Given this list of marker genes Ccdc9b, Glcci1 (glucocorticoid induced transcript 1), Deup1, Thsd7a, Maml3 (NCBI Gene Id 99860), Coq10a, Crot, Ppargc1a, Tead1, Col5a1, Dpysl3 (dihydropyrimidinase-like 3), Jmy, Tanc2 (tetratricopeptide repeat, ankyrin repeat and coiled-coil containing 2), Xirp2, Appl1, Pcdhga12, Utp11 (NCBI Gene Id 67205), Irak1bp1, Ppp3r1, Zfp40, Slc25a17, Sh3pxd2a, Rnf222, Rcan2, Ogt, Zfp329, Nr2e1, Ccser2, Abhd17c, Cldn12, Ncoa4, Tesk2 (NCBI Gene Id 230661), Prol1, Esp36, Prr9, Phf5a, Pkig, Slc38a1 (solute carrier family 38, member 1), Pcgf3, Ube2i, Inpp5a, Casz1, Slc43a2, Serpinb2, Neurod4, Polr3k, Zwint, Cdc37l1, Tdrkh, Mfsd1, Slc25a13, Hmmr, here is a description of the gene set: from publication Chen Y, Wang X (PMID 31504780) studied in species Mus musculus Genes predicted to be targets of miRBase v22 microRNA mmu_miR_879_5p in miRDB v6.0 with MirTarget v4 prediction scores > 80 (high confidence targets). Mouse Gene Set: MIR_879_5P